Given this list of marker genes OXSR1, ENTREP1, STK39, CXCL12, CXCR4, WBP1L, TREM2 (NCBI Gene Id 54209), here is a description of the gene set: The series of molecular signals initiated by the binding of the chemokine CXCL12 to its receptor on the surface of a target cell, and ending with the regulation of a downstream cellular process, e.g. transcription. studied in species Homo sapiens Human Gene Set: GOBP_CHEMOKINE_C_X_C_MOTIF_LIGAND_12_SIGNALING_PATHWAY